The following is a description of a gene set: Human cytomegalovirus (HCMV) induces pro-inflammatory monocytes following infection and we have evidence that phosphatidylinositol 3-kinase is a key mediator in this activation. To begin to address how this signalling pathway is responsible for the functional changes in infected monocytes, we examined the role this pathway played in the transcriptome of infected monocytes. Global transcriptional profiling using cDNA microarrays revealed a significant number of genes were regulated in a PI(3)K-dependent manner, identifying this pathway as a key cellular control point in the conversion of monocytes to an activated pro-inflammatory state following HCMV infection. species: Homo sapiens from publication Chan G, Nogalski MT, Bentz GL, Smith MS, Parmater A, Yurochko AD (PMID 20173022) Human Gene Set: GSE19772_HCMV_INFL_VS_HCMV_INF_MONOCYTES_AND_PI3K_INHIBITION_DN Genes down-regulated in monocytes after HCMV infection: untreated versus pre-treated with Ly294002., and this is the list of marker genes: MAPRE2, TTC39B, TGIF1, RRM2B, EI24, CAMLG, OAZ2, MINPP1, ALG5, PHF5A, UNC119B, CD160, GBE1, ARPP19, CCR5, HEXA, PDS5B, LYSMD2, DOCK5, CCL5, PCBP1, PIP4P2, NUP85, TMEM68, ID2, SNRNP40, DNAJC9, GOLM1, RGS16, TNFRSF18, WLS, GLCE, ARL1, COX17, CASP1, MYO1E, TRAF5, CHCHD7, MEMO1, SWI5 (SWI5 homologous recombination repair protein), RAB8A, U2AF1, EMB, ITM2C, PPP3CB, CA2, DAZAP2, NEDD4, SNX12, SLC44A1 (solute carrier family 44 member 1), CD244, SAR1B, PHYH, PLAC8, DBI, RHOQ, GABARAPL1, RRP1B, SERF1A, AKTIP, SHOC2, LCLAT1, TMEM126A, GANAB, GIMAP4, VAMP4, SRPRB, POLA1, NEDD9, ZNF841, PSMD10, BCL2L11, SLC1A5, SQLE, NUDT4, YBX3, MDFIC, ACADL, IL1R1, KCTD12, CERK, CTNNA1, LAPTM4A, PSEN2, RCN1, LARP7, CCNDBP1, CST7, TM9SF2, ARHGAP21, ARAP3, YIPF1, LITAF, CPE, NR2C2 (nuclear receptor subfamily 2 group C member 2), NAPSA, TCF4, RAD17, KIT, HERPUD1, PTS, PSPC1, LEPROT (NCBI Gene Id 83080), PLSCR1, IMPA1, TFPI, TARS1, ADSS1, TYROBP, CPD, ARL5A, HLA-C, TSC22D1 (NCBI Gene Id 8848), RHOD, XCL1, CREB1, ITGAV, ANKH, UBA3, ARPC3, RRAGA, RBM25, SNX1, EID1, SNX9, PSPH, OCIAD1, FGL2, OSER1, CD9, AHNAK, MCOLN2, SERPINI1, ANXA2, CPT1A, NDE1, ITIH5, PPM1A, ATP6AP2, MSH2 (NCBI Gene Id 8169), ERO1B, GRSF1, OSBPL5, RSAD2, IL7R, RHOT1, PRPF38A, CREBRF, RARS1, GJB2, ODC1, CDCA4, BCL2A1, DAPK2, HELLS, SLC35D1, ST3GAL5, EVI2A, UNC50, SPPL3, RGS2, DECR1, ST3GAL6, BLMH, SLC25A53, CCT7, KLRD1, H1-0, CYFIP1, ASAH1, BLK, SKAP2, TM7SF3, IRAG2, GSTO1, CIAPIN1, PERP, MIEN1, DDC, TNFSF11, HSPA4, NFKB1, EEA1, SRSF9, PRKCH, RCOR1, TP53BP1, ELOA, KLC1, JKAMP, U2SURP, COQ3, XDH, CYTH3, CDCA7L, CHPT1, CYP4V2 (NCBI Gene Id 64587), FASLG, GTF2E2, B3GNT2